Given this list of marker genes THSD7A, CTH, TCTN3, TPD52, MTO1, FBXO3, SOHLH2, ATXN7L3B, LRRC2, PEBP1, CRABP1, FRMD3, CSNK2A1, FA2H, ITPR1, COX8A, GATB, USP9X, NUDT7, TMPRSS2, ARHGAP18, OAT, PTGER3, FBXO21, BCAN, GSTM4, LINC00667, ARFGEF3, ZNF711, ERLIN2, FOLH1, DELE1, SKIC8 (SKI8 subunit of superkiller complex), ADH5, ADCY1, IMPACT, FMO5, RALGPS1, TMEM80, ENOSF1, EGF, TOX3, GAD1, IGF1R, SRR, LDHB, TBC1D9, ABCA5, CYB5A, C1orf226, HSPA9, NEDD4L, CCNB1IP1, THRB, CLDN8, GOT2, PLPPR1, SLC25A36 (solute carrier family 25 member 36), RBM14, PEG3, KLF9, ISCA1, CPEB3, OXCT1, BMP7 (bone morphogenetic protein 7), PCLO, GNAS, LRPPRC, KLHL3, TMEM38B, CEP15, AFDN-DT, BCKDHB, NUDT4, PCBP2, ZBTB43, PHYH, AMT, LPL, ABTB3, ITPR1-DT, ATP5F1A, AK2, FAM171A1, KNG1, UCHL5 (ubiquitin C-terminal hydrolase L5), UAP1, DHTKD1, B4GALNT3, COX7B, SHANK2, COX6C, KLHL24, SP2, PPM1K, GABARAPL1, ALDH6A1, AHCYL1, CLASP2, NAA35, MPC1, DLAT, PRDX3, PAIP1, PPP2R1B, SLK, HERPUD2-AS1, ECI2, LINC02344, PPFIA1, NNT, ATP5MC3, MMUT, APLP2, SRP9, SULT1C2, NEBL, ESRRG, HADHB, NDUFS1, PALM, PRKAA2, AUTS2, WNK1, DBT, GHR, ISOC1, TSPAN7, GPRASP1, SLC16A7, RTN4, COX7C, AASS (NCBI Gene Id 10157), GSTA4, MT-ND5, MACIR, CYCS, SLC22A23, MPPED2, SCML1, TBC1D24, C2orf68, CEP70, FAM83F, RHOBTB3, DSG2, MTR, GMNN, here is a description of the gene set: In this study, we found genes that change expression in the cortex and the medulla of the kidney with age. Some of the genes whose transcripts increase in abundance with age are known to be specifically expressed in immune cells, suggesting that immune surveillance or inflammation increases with age. The age-regulated genes show a similar aging profile in the cortex and the medulla, suggesting a common underlying mechanism for aging. Expression profiles of these age-regulated genes mark not only age, but also the relative health and physiology of the kidney in older individuals. Finally, the set of aging-regulated kidney genes suggests specific mechanisms and pathways that may play a role in kidney degeneration with age. Human Gene Set: RODWELL_AGING_KIDNEY_NO_BLOOD_DN species: Homo sapiens from publication Rodwell GE, Sonu R, Zahn JM, Lund J, Wilhelmy J, Wang L, Xiao W, Mindrinos M, Crane E, Segal E, Myers BD, Brooks JD, Davis RW, Higgins J, Owen AB, Kim SK (PMID 15562319) Genes whose expression decreases with age in normal kidney, excluding those with higher expression in blood.